The following is a description of a gene set: part of: Signaling by AXIN mutants Deletions in the AXIN1 gene have been identified in 2 hepatocellular carcinoma cell lines. These deletions, which remove the N-terminal exons of the gene, compromise AXIN1 expression and result in elevated expression of a TCF-dependent reporter. Reactome Pathway: Deletions in the AXIN1 gene destabilize the destruction complex species: Homo sapiens, and this is the list of marker genes: AXIN1